The following is a description of a gene set: A small, dense body one or more of which are present in the nucleus of eukaryotic cells. It is rich in RNA and protein, is not bounded by a limiting membrane, and is not seen during mitosis. Its prime function is the transcription of the nucleolar DNA into 45S ribosomal-precursor RNA, the processing of this RNA into 5.8S, 18S, and 28S components of ribosomal RNA, and the association of these components with 5S RNA and proteins synthesized outside the nucleolus. This association results in the formation of ribonucleoprotein precursors; these pass into the cytoplasm and mature into the 40S and 60S subunits of the ribosome. species: Homo sapiens Human Gene Set: GOCC_NUCLEOLUS, and this is the list of marker genes: NUSAP1, CDCA8, TXK, COIL, RBMY1J, SNORD58B, SNORA29, SNORD58C, KIF2A, SNORA35, NRXN1, REXO4, SNORD114-11, SNORD115-37, RGCC, MIR3651, SNORD110, XRN2, TIMM44, ZNF106, LBR, SCARNA21, PPID, ELL3, SNAI1, RAI14, DUX4, SNORA80D, TAF1A, SCARNA16, RPS23, WEE1, SNORD116-8, SNORD114-26, DHX37, SNORD83B, KIAA0319L, MIDN, RBM19, SNORD34, EXOSC4, SNORD19, INO80C, SNORD57, BUD23, SNORD90, SMARCA5, WDFY3, TUT1, PKMYT1, GTF3C1, BOP1, SCARNA18B, GTF2H5, GORAB, ANKRD1, TP53, SNORD115-41, TENT4A, RPL27, TAF1C, ZNF174, SNORA70I, SPG11, ZNF622, SCAF11, SCARNA18, GEMIN4, GET4, MAK, DDX11L8, MPHOSPH8, ETV6, SNORD114-3, UTP6, SNORA70J, SNORD113-5, NPM2, MYBBP1A, PECAM1, SNORA46, ZNF641, SNORA35B, RBM4, CHD7, URB1, SNORD12B, SNORA63B, SPATS2L, CASK, SNORD2, PRKDC, SNORA9, RRP1B, CDC14A, ENDOV, XRCC6, WDR46, NOP14, CPS1, SNORA52, POLR2K, ERCC6, SNORA70H, THAP2, SNORD45B, NHP2, RGS22, PAK1IP1, POP5, SNORD115-14, ATF6B, BMS1, ZPR1, CARF, SNORA1, HMGB2, DOCK4, SNORA40C, NSUN5, CCDC137, TFIP11, NACC2, SNORD114-19, NUP153, CUL2, SCN5A, SNORD115-21, ZNF593, URB2, SELENBP1, CEBPA, UTP25, DYNLT4, BNIP2, ZNF330, IPPK, RBPJ, NEK11, NWD1, SNORD114-16, SNORD1C, AK6, MRPL40, CKAP2, IP6K2, PELP1, RPL36, TSR1, ERGIC2, SNORA5C, SNORD18C, NOX4, SNORD50B, SNORA75, TMEM65, SPTY2D1, RRP1, TIMM13, SNORA16B, EEF1E1, SNORD116-27, MPHOSPH10, SURF2, H1-8, RASL11A, IKBIP, BTBD10, SLC30A5, RPL23A, GABRG3, KIF20B, BAZ1B, SNORA75B, L3MBTL1, CENPH, SNORD115-34, SCARNA10, NOL3, POP4, SNORD4B, SPTBN1, SNORD48, RAD51, MBIP, SNORD31B (small nucleolar RNA, C/D box 31B), SNORD115-11, TBP, CTCF, AEN, TXNRD1, LAS1L, STAU2, RBMX2, SNORD104, SNORD9, TTC3, SNORD73A, SNORD115-6, SNORD116-5, SNORD67, GLE1, PHLDA1, PLCZ1, BNC2, PWAR5, ARID5A, SERPINB13, DNAJC21, SNORD121A, POLA1, SNORD114-14, DNAJB9, NOP9 (NCBI Gene Id 161424), FAM193B, VMP1, TSEN2, SNORD111B, YY1AP1, SNORD114-2, MAFIP, SNORD116-20, PAFAH1B2, SNORA50C, NPM1, CPNE3, DDX50, C6orf89, RPS17, GTPBP4, RSL24D1, RPL26, NLRP5, MRPS31 (NCBI Gene Id 112759), HNRNPR, EXOSC3 (NCBI Gene Id 51010), SNORA53, FCF1 (FCF1 rRNA-processing protein), ZZZ3, DDX53, DNTTIP2, SNORD115-23, POLR1H, XPO1, SPECC1, WT1, RSAD2, SIRT6, RBM34, ZCCHC9, SNORD116-18, SNORA71B, SNORA7B, GNAI1, STK24, SRSF9 (serine and arginine rich splicing factor 9), SNORD115-44, RPS6KA3, DDX46, SNORD112, SNORD53B, POLR2I, PLK3, SNORA38B, HOXB5, DEK, RUNX3, SRPK2, SNORD66, SNORA73A, SNORD91A, TOP1, BNC1, SNORD115-33, SENP3, WDR12, SNORA11, KAT5, SNORD20, LIAT1, SNORA68, OLA1, CAMK4, SNORD115-3, NMD3, ABT1, TCEA1, MDFIC, DCLRE1A, SNORD88A, SNORD11B (NCBI Gene Id 100113392), CHCHD1, CDC14B, PPP1R12A, LINC01151, SNORD107, ELP3, PDHA1, JMJD6, SNORD58A, PNKP, NUDT16, SNORA36C, SNORA33, RBMY1E, ARHGAP32 (NCBI Gene Id 9743), PUS1, SNORA3C, SNORD116-22, NOL9, SNORD14C, SNORD94, SAPCD2, ZNF771, SNORD1B, PYM1, SNORD28B, NIFK, RARS1, SNORA38, UBLCP1, SNORD77B, SNORA1B, SNORD37, WRN, POMT2, TAF1B, PNO1, MXI1, RBMY1B, BLM (NCBI Gene Id 641), ARL6IP4, SNORD115-13, RCC2, SNORA24, SNORA57, SNORD108, SIX1, RAN, NFKBIE, MNDA, SNORD114-1, CDC6, ZBTB11, SNORD45C, NIN, ESRRA, METTL1, DROSHA, SNORD7 (small nucleolar RNA, C/D box 7), RPS13, TMA16, SP100, STN1, TGS1, GOLGA3, SNORD115-42, HINFP, SNORD114-25, PAK6, ZNF415, SNORD97, HEATR1, RPL34, ZNF354A, SNHG29, GJB4, DDX31 (DEAD-box helicase 31), KDM2B, GON7, SMUG1, TAF4B, FGF22, ZMAT3, LRP1, SNORD49B, RREB1, CASP7, SNORA2C, EXOSC1, SNORA20, NBN, FOXL2NB, TAF15, UBXN8, PEX14, ATXN3, IDH3G, PAX9, HDHD3, SNORD72, CLEC3B, LEO1, NOC3L, TTC8 (NCBI Gene Id 123016), PCDH1, RPS27A, MCRS1, EXOSC8, RXRB, XPC, NCL, SNORA10, SNORD116-30, NRIP1, MTX2, SNORA41B, SNORD14D, PANK1, PNMA3, FBLIM1, SNORD126, GLI3, SAMD4A, NOP56, SNORA49, SSRP1, SNORA4, TSPYL1, SNORA19 (NCBI Gene Id 641451), RPS19, RASL10A, NSUN2, POLGARF, ELOVL2-AS1, MRM2, MDN1, WDR36, SNORD113-7, G2E3, HAND1, PHF8, KLHL7, SCARNA13, CMPK1, MAD2L1BP, SNORD114-27, SNORD114-21, RBM14, PUM3, RPS24, GTPBP10, DGKQ, NEPRO, WDR55, RIOX1, SNORD113-8, VCX3A (NCBI Gene Id 95334), DTL, SNORD116-19, ILF2, FANCD2, SNORD8, ATXN1L, EZR, NUB1, MED27, SNORD38B, WDR18, HLTF (helicase like transcription factor), SNORD38C, KRR1, SNORA2A, RCL1, ARL4A, SNORD115-31, SNORA27, GCFC2, SP140, EWSR1, CYB561A3, CDK7, SNORD116-12, KIF18B, SNORA80B, KIT, TOP2A, DHX9, ATM, MNX1, SNORD13, RPS19BP1, UTP3, CHP2, SNORD114-23, LLPH, BCKDHB, SYNE2, SNORD88C, SLX9, GRWD1, SNORA80A, FYTTD1, ZNF506, POP7, TRAF4, COX7A2L, SCARNA12, SNORA70B (NCBI Gene Id 100124537), NOC2L, APEX2, C1orf131, BRIX1, FBL, FRG1, SCARNA23, RBM28, ETV4, SNORD116-1 (small nucleolar RNA, C/D box 116-1), SNORA48B (NCBI Gene Id 109616969), ZNF274, SUMO1, MYO10, SNORA66, SNORD115-27, FKBP6, RPP25, SNORD82, SNORD49A, SNORD3J, NFIB, ZNRF2, OSBP, RPP38, SNORD127, CERKL, SNORD54, YPEL2, RNU105B, PYHIN1, SNORD93, SNORA74A, SNORA31, RUNDC3A-AS1, MIR664B, CIPC, ABCC4, SNORA31B, SNORA36A, SNHG1, IMP3, TRMT1L, TERF1, SHLD3, RPAP2, RBBP5, IMP4, SYNE1, ZCCHC4, CDKN2A, PPP1CC, DCAF1, USP14, SNORA28, CCNY, PRKRIP1, SNORA22, PCAT18, DDX54, SNORD116-23, SNORD116-29, LIN28B, NR4A1, SNORD115-22, NOC4L, DEDD2, SNORD115-39, POLR1E, STON2, SNORD1A, PSIP1, SHQ1, SDHAF2, PARN, RPS16, PTH1R, RPL7A, CPT2, SNU13, UTP18, DEAF1, KDM7A, TAF1D, PDHA2, SNORD123, C1QBP, CCNT1, CCND2, SNORD86 (small nucleolar RNA, C/D box 86), SNORD19B, TUT4, SNORA60, TENT4B, SNORD114-7, PHF6, CHRM2, SNORD56, SCARNA7, ZNF16, SNORA25B, NVL, SNORA70E, NF1, COG7, PER2, PARP2, SNORD41, SNORD4A, TRIM41, KLK6, ZNF202, POLR2E, SNORA22B, SNORA63C, ZNF175, CD1E, DDX23, PIM1, JAZF1, CASP2 (NCBI Gene Id 835), HSPA8, TMEM179B, DNAAF2, SNORD13D, OARD1, ACTR6, SNORD115-16, MOB2, PODXL, RPS10, SNORD32A, SNORD115-45, PPP1CA, XRCC5, SNORD3B-1, NUAK1, EXOSC6, SMG6, PARP1, SNORD3G, SNORA70, THUMPD3, SNORA12, CENPP, ZNF207, SNORD91B, CASP1, CCNO, MCM10, MAP1S, CCDC86, RRP8, SNORD114-6, SNORA48, DDRGK1, SNORD63, SETMAR, ANP32B, POU2F3, NPM3, STOX1, STAG2, GZF1, RPP40, TMUB1, DAB2, SNRPB2, RPS14, TRIM68, TWIST2, PIDD1, SNORA70G, SNORA63, NRDE2, RBM4B, RPL5, SNORD12, MTDH, SNORA41, CCR2, PIN4, SNORD115-15, MRPS15, DDX27, ACSL5, SNORD95, PIMREG, P3H4, PDK3, SNORD113-6, PINX1, AKAP11, ADARB2, RNMT, SNORD113-4, RPL23, SMC2, SNORD65, DKC1, SNORD83A, C2CD4A, DDX52, FAM111A, RBM7, TSPYL2, SNORD36C, SNORD115-17, DDX56 (NCBI Gene Id 54606), RETREG1, PLRG1, RERG, RABGEF1, RPS3A, SNORD33, AATF, SNORD84, SNORA17A, EME1, SNORD71 (NCBI Gene Id 768221), RAB8A, SUB1 (SUB1 regulator of transcription), SDAD1, RPL13A, LDB2, SNORA7A, EPC1 (NCBI Gene Id 80314), UCHL5, PIH1D1, TRIM27, EXOSC9, EIF3L, SNAPC1, MRPS9, TRERF1, EIF4A3, DDX18, SNORD116-26 (small nucleolar RNA, C/D box 116-26), SNORD65B, HSD3B2, DHX15, SNORD42B, TOE1, SUZ12, SNORD28, GNL2, RPL35, FAM32A, RRP36, GTF3C3, KDM5A, SNORA3B, YPEL3, SNORD10, MDM2, ZFX, PRMT7, SNORD114-20, SNORD52, FBLL1, SNORD38A, TTF1, TAF13, POLR2H, SCARNA9, MIF4GD, SF3B1, TULP3, RRN3, MCM7, CHTOP, SNORD24, SCD, AGPAT5, BRWD1, FOXJ2 (forkhead box J2), RAD17, SNORD116-15, ORC4, PPM1D, ZNF692, SNORD116-10, REXO5, COX10, HJURP, NSA2, DDX5, SNORA54, POLR1D, SNORA30, BATF3, MYCN (MYCN proto-oncogene, bHLH transcription factor), CD2AP, CKAP5, RBIS, DDX49, BAZ2A, GPATCH4, GPRC5A, RPS5, ABHD14B, DUSP11, SNORD115-8, SNORA36B, SNORA65, ADAD1 (NCBI Gene Id 132612), CETN3, STAG3, ANG, PTBP1, HTD2 (hydroxyacyl-thioester dehydratase type 2), LRWD1, SNORA40, HSD3B1, ZFP69B, SNORA74B, VCX3B, SNORA70D, MKS1, WDR74, WDR3, ATP8B2 (NCBI Gene Id 57198), ABCB8, DDX21, SNORD13E, S100A13, SNORD69, S100A16, SNORA25, TSEN15, UTP15, DDX10, DIMT1, ANAPC11, EDF1, SCARNA3, SNORD111, YPEL4, NEDD1, SAP30L, RPS6KA6, LETMD1, PRMT2, DDX55, MRPS27, UBA2, SNORA70C, SNORD63B, SNORD116-13, ZEB2, MYC (MYC proto-oncogene, bHLH transcription factor), SNORD116-6, PRDM5, LIPA, KIF7, EIF6, TRA2A, MALT1, WDR43, SNORD121B, RPS7, SNORD115-2 (NCBI Gene Id 100033437), IFT88, ZNF385A, POLR1A, SNORA63E, TRMT10A, SNORD114-12, HOXD9, SNORA17B, SNORA11G, SIRT2, BCAS2, SNORA26 (small nucleolar RNA, H/ACA box 26), DDX51, VPS51, PDCD11, CD2BP2, IER5, NAA50, SNORD65C, TAOK2, RPS9, SNORD3C, SNORA16A, PLK5, EMG1, SIRT1, SNORA55, NUFIP1, SNORA9B, RPS6, POLR2L, SNORD70B, FTSJ3, ZNF300, NLRP1, L3MBTL3, SNORD3E, NOL4, SNORD16, SNORD115-10, SNORD36B, SNORD3A, MAK16, MPHOSPH6, PPAN, DFFB, SRP54, RBMY1A1, SNORD92, SNORA2B, SNORA15B-1, SNORD51 (small nucleolar RNA, C/D box 51), SCARNA21B, CSNK2B, SNORD124, SLBP, HABP4, SNORA74C-2, HUS1B, DCTN3, SNORA24B, SNORA71D, SNORD101, KNOP1, SNORD55, SPRN, SNORD27, TSG101, SNORD98, FIRRM, FEN1, WDR33, PARP10, NGDN, CEMIP2, RELA, XRCC1, ZMYND8, APEX1, PLEKHM1, MARCHF6-DT, GPER1, BYSL, CBX5, RPL18, SNORD87, NAA10, TRAF3IP1, SNHG7, SNORA11F, ERI1, LARP4B, OASL, RPS28, STAT1 (NCBI Gene Id 6772), DIAPH2, ITGB4, RDM1, SENP5, SNORD116-3, TAF1, UTP14A (NCBI Gene Id 95977), SNORD14A, SCARNA2, METTL18, RPS11, AKNA, SNORD115-35, VCX, KAT7, FXR1, AOPEP, DYNC2I2, DYRK1B, SNORD64, H1-10, SRP68, RNF20, SNORD68, SNORD116-21, SNORD105, PHF2, ITPR3, GEMIN2, DCAF17, NOLC1, RPP21, ISG20, SNORA70F, WDR75, SNORD138, KRT18, UTP14C, MED1, DNTTIP1, ARL4D, RNU105C (NCBI Gene Id 26766, RNA, U105C small nucleolar), FBXL22, SLC29A2, RPS15A, ARFIP2, SNORD88B, RBM10, FBXW7, NOP2, SNORA32, REV3L, SDCBP2, SNORD115-4, RPL11 (ribosomal protein L11), SNORA77, RBBP6, BEND3, SNORD45A, ZNF346, RPP30, OTP, RPS2, HNRNPM, NOL11, NONO, SNORD35B, RPAIN, RPL13, BCL6, FGF18, DDX28, ZBTB14, SNORD3H, CC2D1A, DDX11, SCARNA5, LSM6 (LSM6 homolog, U6 small nuclear RNA and mRNA degradation associated), SNORD115-28, WASHC2A, INO80B, NAT10, SNORD116-2, SNORA51, SNORA74C-1, ATXN7, SNORA6, RAE1, SNORD105B, GPATCH2, SNORD61, PA2G4, SNORD114-18, RPS12, EXOSC2 (exosome component 2), SNORD43, SKP2, SCARNA11, MRTO4, POLR1F, CENPW, SNORD17, DNAJC2, TSEN54, PLK4, EIF3A, ZCCHC7, ATF3, SNORD35A, KRI1, SNORD15B, SNORA11D, SNORA5B, OXR1, SNORD115-30, MAP3K14, DEDD, RBMY1D, RPF1, RRP7BP, HAUS7, CHD3, SNORD115-32, BCL9L, MAGI1, APTX, GET3, SNORA37, CDK8, MIR1248, SNORD115-20, MTUS1, RPL4, ADAR, ZNF432 (zinc finger protein 432), MYSM1, PWP1, TOP2B, TAF5, SNORD30, SCARNA20, PWP2, PLSCR1, ZNF655, SNORD21, SNORA14A, UBTF, MIR6516, NOM1, UPF3A, TBL3, SNORD115-25, ATXN1 (NCBI Gene Id 7912), DDX17, SNORD100, SUV39H1, E2F8, MLLT1, SNAPC5, SNORD115-46, INO80E, NF2, CLN6, PPP1R26, CDK4, MAPKBP1, NARF, SNORD18A, SNORD15A, GLI2, NLE1, SNORD14B, RIOX2, AGER, EMX1, DNAAF5, TP53TG5, SNORD114-10, ARL2, TAX1BP3, AKAP8, SF3B3, SNORA8, SNORD114-31, SCARNA8, MCIDAS, SNORA58B, SNORD115-40, ZC3H14, DCAF13, NOL6, RGS2, XPO6, TERT, SNORA3A, LIN28A, SETX, SNORA14B, DHX33, TSEN34, ABL1 (ABL proto-oncogene 1, non-receptor tyrosine kinase), SNORA62, RBL2, MRPL23, USP36 (ubiquitin specific peptidase 36), NHEJ1, HUS1, FLNA, KAT6A, BMAL2, SNORA30B, POLN, PPM1E, SNORD109A, DGCR8, SMARCA4, FBXO25 (NCBI Gene Id 26260), SNORD115-1, STK35, DAXX, SNORD46, SNORA71C, CSTB, SNORA5A, EXOSC7, MTREX, LYAR, UTP20, SNORD12C, RPS27, SNORA73B, SPATA2, ZNF501, PAF1, SNORA50D, TNPO1, TEX10, MBD6, HSPA9, IGF1R, SNORD18B, MUS81, RRS1, SNORD115-24, NOP16, SCARNA6, SNORD115-7, NUCKS1, SNORD70, SNORA71A, SNORA67, SNORD117, GPRC5B, SNHG10, DNAJB1, IFI35, SNORA72, SNORD22, SNORD115-38, SRSF5, KDM4A, SIRT7, NOP53 (NCBI Gene Id 94457), ISG20L2, UTP11, ABTB1, SIN3A, MEAF6, SETD7, SNORD60, SURF6, TNP2, UBD, DDX24, ZBTB33, C19orf33, PYCARD (NCBI Gene Id 29108), WDFY1, HOMEZ (NCBI Gene Id 57594), RRP9, CDKN1A, HAP1, SNORA18, SNORA69, H1-5, SNORA40B, RPS3, RPL7L1, RBMY1F, SNORA50A, DDB1, CRADD, PIK3CB, UBE2T, NOVA1, MRI1, SNORA11B, MACROH2A1, SCARNA17, CIAPIN1, SNORA22C, NOL10, PES1, SNORD114-24, RNF169, RPL7, CDKN2AIP, RPF2, NIP7, KDM5D, SPIN1, SCARNA22, SCARNA15, SNORA80C, SNORD116-14, CBFA2T3, SNORD73B, FILIP1, FOXI1, SNORA50B, ZFP91, SNORA47, MEAK7, SBDS, KATNBL1, FAM9A (NCBI Gene Id 286475), ZBED6 (NCBI Gene Id 100420762), POLR1B, RPS25, PPM1B, SNORA79, SNORA11C, ORC6, MCM3, RPS8 (ribosomal protein S8), DDX47, ZCCHC8, ADAD2, FMN2, POLR1G, LRRC34, MAGED2, TRAIP, CAPG, NOL7, ATP5MJ, RCN2, FHIT, SNORD11, SNX15, SNORD32B, FST, ILF3, SNORA59B, PANO1, SNORD116-16, MRO, NFX1, SNORD99, REXO2, RPP14, FMR1, RGS12, ZNF397, ARL14EP, ARFGEF1, SNORA84, SMAD7, SNORA10B, THAP1, MYO1C, SNRNP35, METTL5, ALKBH4, MCM2, GAR1, SNORA44, AXIN1, TXN2, ZNF146, SNORA71E, ARHGAP33, PTPN6, SNORD114-13, RNF213, PNMA1, SNORD115-26, SNORD115-9, KLLN, EEF1A1, UTP23, ADARB1, VRK1, SNORD113-9, SNAPC3, ZNF554, IFI16, SCARNA14, SNORA58, MKI67, NOP58, SNORD36A, SNORA56, NEK2, MARS1, SNORD114-5, FBXO11, SNORD114-17, USO1, CAPN3, NANOG, HIRIP3, PRDM1, ACACA, PRMT6, SPATA24, SNORD114-29, SDHA, SNORD6, UTP4 (NCBI Gene Id 84916), SNORD116-4, CDCA7L, CD180, EBNA1BP2, LDOC1, PYDC2, SNORD81, PTPRJ, SNORD26, CDC14C, XNDC1N, RRP12, RTF1, SNORA21, SNORD23, SNORD59A, SNORA61, KLF6, SNORD3D, CEP85, PNMA2, WDR82, SNORA20B, INTS4, DSN1, SNORD74B, SNORA79B, POP1, ESF1, MIR664A, POLR1C, CUTC, MYG1, DNMBP, SNORD114-9, TBCA, SNORA80E, SNORD116-24, SNORD114-22, PPP1CB, RPL19, SNORD5 (NCBI Gene Id 692072), RSL1D1, EN2, SNORD53 (small nucleolar RNA, C/D box 53), HERC4, LCA5, SNORD89, RBM15B, SFR1, SESN1, IPO5, ACADVL, AIRIM, METTL22, USP17L24, CA9, GNAI3, RPL3, SNORA68B, SNORA78, SNORD115-5, SMARCB1, AFF4, FOXA1, SRP19, CHRNA3, SNORD62A, C1D, IP6K1, MORF4L2, RARA, UPF3B, TCOF1, GNL3, CBY1, NKRF, RORA, SNORA77B, RELT, SNORD114-4, SCARNA1, ZFC3H1, NOL12, SNORD102, PML, ALKBH2, MACROD2, SNORA64, SNORD114-28, ZFY, CAMKMT, WASHC2C, SNORA13, EXOSC10, INKA2, SNORD116-11, SNORD114-30, SNORD116-25, ITPR1, GNL3L, RRP7A (ribosomal RNA processing 7 homolog A), SNORA15, NOL8, POLR2F, SNHG12, E2F5, TDP2, SNORD38D, SNORD125, SNORD114-15, SPC24, NOP10, SNORD115-48, EID3, N4BP1, PARP3, SCARNA4, TCIM, PSPC1, EEF1D, POLR2A, SNORD56B, SNORD113-3, RPS4X, CEMIP, NFIC, KMT5B, DIS3, EXOSC5, NSD2, ZCCHC17, CDK5RAP3